The following is a description of a gene set: Human Gene Set: LE_NEURONAL_DIFFERENTIATION_DN from publication Le MT, Xie H, Zhou B, Chia PH, Rizk P, Um M, Udolph G, Yang H, Lim B, Lodish HF (PMID 19635812) studied in species Homo sapiens MicroRNAs (miRNAs) are a class of small noncoding RNAs that regulate gene expression at the posttranscriptional level. Research on miRNAs has highlighted their importance in neural development, but the specific functions of neurally enriched miRNAs remain poorly understood. We report here the expression profile of miRNAs during neuronal differentiation in the human neuroblastoma cell line SH-SY5Y. Six miRNAs were significantly upregulated during differentiation induced by all-trans-retinoic acid and brain-derived neurotrophic factor. We demonstrated that the ectopic expression of either miR-124a or miR-125b increases the percentage of differentiated SH-SY5Y cells with neurite outgrowth. Subsequently, we focused our functional analysis on miR-125b and demonstrated the important role of this miRNA in both the spontaneous and induced differentiations of SH-SH5Y cells. miR-125b is also upregulated during the differentiation of human neural progenitor ReNcell VM cells, and miR-125b ectopic expression significantly promotes the neurite outgrowth of these cells. To identify the targets of miR-125b regulation, we profiled the global changes in gene expression following miR-125b ectopic expression in SH-SY5Y cells. miR-125b represses genes that contain the seed match sequence of the miRNA and/or that are predicted to be direct targets of miR-125b by conventional methods. Pathway analysis suggests that a subset of miR-125b-repressed targets antagonizes neuronal genes in several neurogenic pathways, thereby mediating the positive effect of miR-125b on neuronal differentiation. We have further validated the binding of miR-125b to the miRNA response elements of 10 selected mRNA targets. Together, we report here for the first time the important role of miR-125b in human neuronal differentiation. Genes down-regulated during neuronal differentiation of SH-SY5Y cells (neuroblastoma) in response to stimulation by tretinoin (all-trans retinoic acid, ATRA) and BDNF., and this is the list of marker genes: CKS2, EIF4EBP2, E2F7, SEMA5A, CCNT1, UBE2C, CDC20, SUV39H1, SFXN2, PKMYT1, MSI1, E2F2, LHX6, KIF23, RGS12, CCNB2, MRPL11, CDK4, CDC25C